The following is a description of a gene set: studied in species Homo sapiens Abnormality of foveal pigmentation An anomaly of the pigmentation in the fovea centralis. Human Gene Set: HP_ABNORMALITY_OF_FOVEAL_PIGMENTATION, and this is the list of marker genes: IMPG1, CTNNA1, CFHR1, SLC38A8, RAB28 (NCBI Gene Id 9364), HMCN1, CFHR3, APOE